Given this list of marker genes Vopp1, Cdk6, Ccdc126, Smad1, Adss1, Uchl1, Ccnd1, Alcam, Rnf125 (ring finger protein 125), Pik3cb, Slc30a1, Atf3, Tfpi, Zfp14, Atxn1, Abtb2, Xlr3a, Bhlhe40, Nrip1, Cers6, Rnf43, Pla2g4a, Mt1, Pcp4, Kcnf1, Ppargc1a, Kif13a, Xist, Slc47a1, Cdc42bpb, Gpr65, Mthfd2l, Ckb, Abcb1b, Asns, Pllp, Jun, Mei4, Cd69, 4921525O09Rik, Ctsl, Bhlhb9 (NCBI Gene Id 70237), Serpinb1a, Bcl11b, Tmem38b, Fam221a, Dnai2, Ret, Trim12a, Tspan4 (tetraspanin 4), Obscn, Isl1, Enah, Aig1, Fabp5, Acot1, Sfmbt2, Rab20, Trps1, Shcbp1l, 2900026A02Rik, Acoxl, Trmt61a, Garem1, Ak7, Lncpint, Prss23, Klf7 (NCBI Gene Id 93691), Ccnd2, Rab30 (NCBI Gene Id 75985), Tln2, Eid2, Grik1, Xlr4b, Rragd, Kcnq1ot1, Gphn (gephyrin), Lgalsl, Eqtn, Zfp827, Laptm4b, Ptpdc1 (protein tyrosine phosphatase domain containing 1), Mt2, Plk2, Ccdc91, here is a description of the gene set: species: Mus musculus Multiple myeloma is an incurable plasma cell malignancy for which existing animal models are limited. We have previously shown that the targeted expression of the transgenes c-Myc and Bcl-X(L) in murine plasma cells produces malignancy that displays features of human myeloma, such as localization of tumor cells to the bone marrow and lytic bone lesions. We have isolated and characterized in vitro cultures and adoptive transfers of tumors from Bcl-xl/Myc transgenic mice. Tumors have a plasmablastic morphology and variable expression of CD138, CD45, CD38, and CD19. Spectral karyotyping analysis of metaphase chromosomes from primary tumor cell cultures shows that the Bcl-xl/Myc tumors contain a variety of chromosomal abnormalities, including trisomies, translocations, and deletions. The most frequently aberrant chromosomes are 12 and 16. Three sites for recurring translocations were also identified on chromosomes 4D, 12F, and 16C. Gene expression profiling was used to identify differences in gene expression between tumor cells and normal plasma cells (NPC) and to cluster the tumors into two groups (tumor groups C and D), with distinct gene expression profiles. Four hundred and ninety-five genes were significantly different between both tumor groups and NPCs, whereas genes were uniquely different from NPCs in tumor group C and genes were uniquely different from NPCs in tumor group D. Similar to human myeloma, the cyclin D genes are differentially dysregulated in the mouse tumor groups. These data suggest the Bcl-xl/Myc tumors are similar to a subset of plasmablastic human myelomas and provide insight into the specific genes and pathways underlying the human disease. from publication Boylan KL, Gosse MA, Staggs SE, Janz S, Grindle S, Kansas GS, Van Ness BG (PMID 17483317) Top up-regulated genes from principal component 3 (PCA3) which captures variation among different plasma cell tumors arising from overexpression of BCL2L1 and MYC. Mouse Gene Set: BOYLAN_MULTIPLE_MYELOMA_PCA3_UP